The following is a description of a gene set: Human Gene Set: GSE16386_IL4_VS_IL4_AND_ROSIGLITAZONE_STIM_MACROPHAGE_6H_UP Human CD14 positive monocytes were purified from healthy volunteers’ blood and cultured in vitro for 6 hours. While culturing, macrophages were activated alternatively with interleukin-4 (IL-4 100 ng/ml). Simultaneously, macrophages were also treated with vehicle (DMSO:ethanol) or 1uM synthetic PPARg agonist, Rosiglitazone. We used Affymetrix microarrays (U133Plus 2.0) to analyze activation and PPARg-induced gene expression changes. species: Homo sapiens Genes up-regulated in macrophages (6h): IL4 versus IL4 and rosiglitazone. from publication Szanto A, Balint BL, Nagy ZS, Barta E, Dezso B, Pap A, Szeles L, Poliska S, Oros M, Evans RM, Barak Y, Schwabe J, Nagy L (PMID 21093321), and this is the list of marker genes: GSTM3, ANKRD54, SNRPD2, POLE (NCBI Gene Id 80252), GARS1, HOOK2, DGCR8, AP2M1, ZNF32, EEF1D, OXT, SFMBT2, DPF1, ZC3H7B, SPI1, PNKD, ZNF777, TUBGCP6, KCNAB2, OLA1, CPT2, MAPK8IP3, UXS1, MRPS6, MINDY4, MZT2B, SLC35G1, RCCD1, BCKDK, MLLT1, CTH, WIPI2, SMIM20, MRPS24, ISY1, MATN2, TAF8, ADAM9, UCHL5, DERL2, KAT14, MTF2, WDR74, PRKDC, ACP6, PHB1, BDH1, RNASEH2A, MRPL16, GTF2IRD1, AARSD1, SNRNP25, RRS1, BORCS7, PRODH, NUDT7, RBM22, GCKR, IDH2, AP4M1, CUL2, RCN2, FHOD1, FAM220A, LIN9, CHEK1, HNRNPA1, MRPS18A, PPP6R3, RNMT, GTPBP3, HSPE1, C3orf62, NT5C3B, LRRC8D, EXOSC1, CCDC51, CYB561D2, QPCTL, PTPN9, DNAJC21, SWI5, CBR1, RAD18, ASPM, PKP4, POLR2I, PI4K2B, DNAJC15, PLBD2, SEC11A (SEC11 homolog A, signal peptidase complex subunit), PTPA, STAM, TLCD1, EIF2S1, BANF1, MRS2, B4GALT1 (NCBI Gene Id 2683), DDX3X, EIF2B1, TRMT6, COQ8B, RAD54L, SASS6, ATP9B, DBI, TCHP, ARMCX4, PPM1A, UBE2N, USP2, CPN2, TANGO6, CDKL3, PARP16, SNX7, GNPAT, GBA2, ASXL2 (ASXL transcriptional regulator 2), BAG1, MECR, SLC1A5, MYL4, CCT6A, MRPS35, HOXA4, ACAA1, TEX19, METTL22, CNIH1, LMF1, TECR, MATK, GOLM2, NUP42, IFFO2, MAPKAPK5, ZMAT2, H2AX, BUB1B, RHBDF1, TRUB1, ROPN1L, RRP36 (ribosomal RNA processing 36), TARS1, HSD17B12, PPIH, STXBP4, SMPD4, WDR77, IBA57, MRPS18B, GTPBP4, FZD2, KIAA0753, ITGB3BP, PGPEP1, TIMM50, SLC35A4, MRPL10, SMC2, AP3S1, ATG2A, RBFA, NRROS, LARP7, CSNK1G2, PGF, CALU, SAP30L, SLC28A2, PPP2CB, FAM216A, UTP11 (NCBI Gene Id 51118), FRMD6, FAM98A, PAG1, SPRTN, YJU2, IDO2, RINT1, SH2B2, AARS1, GSTM4, NUP54, SLC2A9, COMT, KXD1, FANCF, ZPR1, NONO, IPO9, LUC7L3, TOPBP1, LDB1, DRG2, CCAR1, DNAJC10, LAS1L